The following is a description of a gene set: species: Homo sapiens Genes having at least one occurrence of the motif SAAAAANNN in the regions spanning 4 kb centered on their transcription starting sites. This matches the ZNF384 transcription factor binding site V$CIZ_01 (v7.4 TRANSFAC). Human Gene Set: CIZ_01, and this is the list of marker genes: SYTL2, PCDH11X (NCBI Gene Id 93452), IGF2BP3, ZBTB20, TXNDC5, TREX2, RNF43, HPSE2, TUBGCP4, REPIN1, DGKA, METTL9, COL3A1, TYRO3 (NCBI Gene Id 7301), TCF7L1, HIVEP1, C6orf62, TRERF1, PTCHD4, CCDC88A (NCBI Gene Id 731560), SLC4A5, SEMA3A, DOCK8-AS1, NFIX, CFI, EHMT2, ERG, EDAR, ZIC4, CHD2, GAL3ST4, SENP1, PCDH12, PURA, PLAG1, ZFPM2, TMPO, H3-3B, TBL1Y, IRAG2, REG4, HNRNPD, CCDC6, NPR3 (NCBI Gene Id 79614), PCDH7, TMEM182, PPP1R10, SYN2, NR5A2, HNRNPR, COL16A1, BTC, CRK, SEMA4G, CCND1, MMP2, PNMA1, LMO3, HOXA2, BATF, NDP, PHF21A, LBX2-AS1, ATXN7L1, EFNA5, LAMP2, GTF2A1L, OFCC1, GLS, SVOPL, CAB39L, TBC1D5 (TBC1 domain family member 5), LYPD1, SPOCK2 (NCBI Gene Id 9806), HOXB7 (homeobox B7), SLC8A3, LYST, MIR1-1HG, NPVF, NCAM1, ARX, GSK3B (NCBI Gene Id 2932), OVOL2, PLEKHO1, HOXB3, GPX1, IKZF2, FOXP3, FBXW4, PWWP2B, ASB15, FOXF2, PYM1, STIM1, BCL9, NRIP2, PDE4D, BCL11A, TOB1, BCL11B, NLK, TLX1, ZSCAN29, PRICKLE1, SLC23A3, ZNRD2, PLP1 (proteolipid protein 1), ADRA2B, C2orf69, TECTA, GLRA2, ACKR3, FGF14, KDM6A, TENT5A, RBM43, FILIP1, CNIH2, PPP2R5D, PAX1, PPP2R1B, DLX5, FAM53B, PCDH11Y, ESM1, WDTC1, PSMD11, HOXC5, SLC4A1AP, CDK18, MYOCD, WNT5A, CCDC148, ADAMTSL1, ECHDC2, FLI1, ZNF654, PDXDC2P-NPIPB14P, TBL1X, NABP2, PKP4, CACNG3, SNCAIP, MGAT4C, TGFB3, INTS4P1, KLF7, RFX4, WWP2, PAPPA, ABCB10, INTS8, TMEM229B, AQP4, PDGFB, COL27A1 (NCBI Gene Id 85301), PRRX1, HOXB9, CCND2, FRMD5, ZNF513, PAXIP1, DMTF1, CRMA, PDCD10, NR2F2 (nuclear receptor subfamily 2 group F member 2), ASIC2, ZNF408, CNTLN, MAP1A, MRPS18B (mitochondrial ribosomal protein S18B), ZMYND8, GPR174, IFT57, NRG2, SLITRK2, TDRD7, ODF1, ARHGAP1, SMARCA2, COA3, GSX1, SGIP1, PHF6, NR4A2 (NCBI Gene Id 4929), SOAT1, PITPNC1, TMSB4XP1, LINC00470, JPT2, CAPG, COLCA1, GPR182, KIT, FLRT3, KLF12, CCSER2, BLOC1S5, LDLRAP1, GPR52, IGSF3, ELAVL2, YRDC, PHOX2B, LUC7L3, ADNP, GABARAP, MBNL1, CAST, AQP4-AS1, CCDC174, WAPL, ZIC1, ZEB2, GRM3, TNKS1BP1, FOXD3, CHCHD7, ST6GALNAC5, TULP4, ID2, VCL, RELCH, MEIS2, C1orf122, ZBTB18, POLR2A, CARMIL1, TCF4, CNTD1, HIP1 (huntingtin interacting protein 1), NKX2-2, SEMA3F, TGIF2, TMEM164, RIMS3, MROH2B, KRT18P55, FAM89B, BORCS6, FOXP2, ADAMTS17, MYLK, PPP2R3C, YWHAG, PAK1IP1, CDKN2C, TAB3, GADD45G, CKAP4, BLNK, FAM110D, KCNJ13, BNC2 (NCBI Gene Id 54796)